Given this list of marker genes Necap1 (NCBI Gene Id 67602), Clint1, Vamp2, Atp6v1d, Pef1, Rab3a, Snap91, Ap2a1, Gad1, Ap1m1, Clba1, Eps15, Sec22b, Syt11, Ap4b1, Ap3b1, Dab2, Furin, Vti1a (NCBI Gene Id 70938), Atp6v1e1, Atp6v1c1, Necap2, Ap3b2, Cltc, Scap, Rnasek, Kdelr1, Vma21, Atp6v0a1, Sar1a, Slc17a8, Trf, Atp6ap1, Otof, Vamp3, Ap1g1, Cemip, Ap2a2, Sec23b, Slc18a3, Uso1, Syn1, Ap2b1, Tepsin, Scyl1, Sec24d, Atp6ap2, Ap2m1, Slc30a5, Hip1, Reep6, Sec31a, Dnajc5, Srebf2, Ston1, Gad2, Cltb, Atp6v1f, Atp6v1g2, Copg1, Vti1b, Sec13, Atp6v0b, Ston2, Ap1g2, Sec16b, Atp6v0e2, Syp, Srebf1, Copa, Arcn1, Ap1s1, Atp6v1a, Cope, Ap1m2, Stx17, Tbc1d5, Copz2, Tmed2, Tmem199 (NCBI Gene Id 97763), Sgip1, Tyrp1, Adcy8, Pdcd6, Tmed3, Rassf9 (Ras association (RalGDS/AF-6) domain family (N-terminal) member 9), Copz1, Atp6v1b2 (NCBI Gene Id 97492), Epn3, Atp6v0d1, Clta, Kdelr2, Ap2s1, Sec24c, Dbnl, Dennd1a, Hip1r, Cideb, Golga5, Sec24a, Synrg, Sec23ip, Sar1b, Copg2, Klhl12, Aftph, Btbd8, Ap1s2, Arc, Sec31b, Kdelr3, Epn2, Sec16a, Gosr2, Atp6v1h, Enthd1, Ap1b1, Nrgn, Dipk2a, Sec24b, Ap1s3, Sec23a (SEC23 homolog A, COPII coat complex component), Copb2, Atp6v0c, Copb1, Epn1, here is a description of the gene set: The lipid bilayer surrounding a coated vesicle. Mouse Gene Set: GOCC_COATED_VESICLE_MEMBRANE species: Mus musculus